Given this list of marker genes RPGRIP1, VPS41, ATRNL1, AP4E1, RPGRIP1L, LRRTM2, ASTN1, DIO1, ZNF10, ZNF264, WIPF1, ZNF177, ZNF154, CASQ2, MTRF1L, CRISP1, SMG7-AS1, IFNA4, RFPL3S, CHRNA3, BCLAF3, SMYD2, ART3, BAAT (bile acid-CoA:amino acid N-acyltransferase), DCC, CUL3, TBC1D31, RBM17, TPH1, ANGPTL7, UGT2B4, GRM8, DMP1, NALF2, AKAP5, IREB2, NELL1, AKR1D1, DFFB, DCAF4, ZBTB25, RFPL1S, GK2, LCT, OPHN1, ST8SIA4, TBC1D12, HDAC9, COCH, DZIP1, MPPED2, ORC4, HCG4, here is a description of the gene set: Human Gene Set: MORF_ZNF10 studied in species Homo sapiens Neighborhood of ZNF10 Neighborhood of ZNF10 zinc finger protein 10 in the MORF expression compendium